The following is a description of a gene set: Any process that prevents the establishment or decreases the extent of the excitatory postsynaptic potential (EPSP) which is a temporary increase in postsynaptic potential due to the flow of positively charged ions into the postsynaptic cell. The flow of ions that causes an EPSP is an excitatory postsynaptic current (EPSC) and makes it easier for the neuron to fire an action potential. Mouse Gene Set: GOBP_NEGATIVE_REGULATION_OF_EXCITATORY_POSTSYNAPTIC_POTENTIAL studied in species Mus musculus, and this is the list of marker genes: Eif4a3l1, Tmem25, Eif4a3l2, Nlgn3, Npy2r, Eif4a3, Mtmr2, Celf4, S1pr2, Nlgn4l, Prkn, Plk2, Lrrk2, Pten, Cbln1 (NCBI Gene Id 12404)